The following is a description of a gene set: from publication Baris O, Mirebeau-Prunier D, Savagner F, Rodien P, Ballester B, Loriod B, Granjeaud S, Guyetant S, Franc B, Houlgatte R, Reynier P, Malthiery Y (PMID 15806164) Human Gene Set: BARIS_THYROID_CANCER_DN The oncogenic pathways in mitochondrial-rich thyroid carcinomas are not clearly understood. To investigate the possible implication of mitochondrial abundance in the genesis of thyroid tumors, we have explored the gene expression profile of six oncocytic carcinomas and six mitochondrial-rich papillary carcinomas using cDNA-microarray technology. A supervised approach allowed us to identify genes differentially expressed in the two types of carcinoma. These genes were classified according to their ontologic profiles. Three genes, NOS3, alpha-actinin-2 and alpha-catenin, suspected of playing a role in tumor genesis, were explored by quantitative RT-PCR analysis and immunohistochemistry. Of the genes overexpressed in papillary carcinomas, 51% were involved in cell communication. Of the genes overexpressed in oncocytic carcinomas, 84% were involved in mitochondrial and cellular metabolism. Our results suggest that mitochondrial respiratory chain complexes III and IV play a significant role in the regulation of reactive oxygen species production by oncocytic tumors. Genes down-regulated in oncocytic follicular carcinoma (FTC) vs mitochondrial-rich papillary carcinoma (PTC) types of thyroid cancer. studied in species Homo sapiens, and this is the list of marker genes: RB1, RPL13A, KLF5, UBE2C, FNTA (NCBI Gene Id 2339), CD2, EVPL, FGFR4, OSBPL1A, SEPTIN2, INPP5D, ERBB2, CD40LG, SNRPF, GLG1, DUSP6, TOP2B, SMARCA5, SRPRA, USP1, ATF1, RAF1, UBA1, IGF1R, FGB, COL8A1, LMO7, CCND1, TGFB1, CD44, ACY1, LLGL1 (NCBI Gene Id 3996), ANXA4, MMP2, TIMP1, BGN, CSNK2B, VCL, PKN3, RECQL, HDGF, GRB7, CALM2, NEDD8, CDH3, KLHL9, RAB8A, ABCC3, IRF1, TNFSF10, SP110, RAD50, IL13RA1, CCND2, GATA3, CYTH1, TNFSF13, CTNNA1, TJP2